The following is a description of a gene set: Enables the transfer of pyruvate, 2-oxopropanoate, from one side of a membrane to the other. studied in species Mus musculus Mouse Gene Set: GOMF_PYRUVATE_TRANSMEMBRANE_TRANSPORTER_ACTIVITY, and this is the list of marker genes: Slc16a11, Mpc1, Slc16a7, Mpc2, Slc16a3